The following is a description of a gene set: part of: Downstream signaling of activated FGFR4 Reactome Pathway: FRS-mediated FGFR4 signaling studied in species Mus musculus This event has been computationally inferred from an event that has been demonstrated in another species.<p>The inference is based on the homology mapping from PANTHER. Briefly, reactions for which all involved PhysicalEntities (in input, output and catalyst) have a mapped orthologue/paralogue (for complexes at least 75% of components must have a mapping) are inferred to the other species. electronically inferred by orthology from the curated human pathway, and this is the list of marker genes: Frs2, Hras, Fgf6 (fibroblast growth factor 6), Fgf17, Fgf23, Grb2, Fgf4, Klb, Fgf16, Fgf15, Fgf20, Fgf8, Fgf1, Fgf2